Given this list of marker genes Rps27a, Tlr4, Cd14 (NCBI Gene Id 12475), Ly96, Ubb, Optn, Traf3, Ticam2, here is a description of the gene set: electronically inferred by orthology from the curated human pathway This event has been computationally inferred from an event that has been demonstrated in another species.<p>The inference is based on the homology mapping from PANTHER. Briefly, reactions for which all involved PhysicalEntities (in input, output and catalyst) have a mapped orthologue/paralogue (for complexes at least 75% of components must have a mapping) are inferred to the other species. studied in species Mus musculus Reactome Pathway: Regulation of TBK1, IKKε (IKBKE)-mediated activation of IRF3, IRF7 part of: Activation of IRF3, IRF7 mediated by TBK1, IKKε (IKBKE)